The following is a description of a gene set: Any process that modulates the frequency, rate or extent of amyloid fibril formation. Mouse Gene Set: GOBP_REGULATION_OF_AMYLOID_FIBRIL_FORMATION species: Mus musculus, and this is the list of marker genes: App, Hspg2, Apoe, Pfdn4, Clu, Pfdn5, Psen1, Pfdn6, Chrna7, Usp8, Trem2, Ldlr, Cryab, Pfdn2, Pfdn1, Vbp1